Given this list of marker genes Jak2, Raf1, Ifngr2 (interferon gamma receptor 2), Mapk1, Ifngr1, Mapk3, Ifng, here is a description of the gene set: IFNG signaling activates MAPKs Mouse Gene Set: REACTOME_IFNG_SIGNALING_ACTIVATES_MAPKS species: Mus musculus